The following is a description of a gene set: Prognostic signatures in breast cancer derived from microarray expression profiling have been reported by two independent groups. These signatures, however, have not been validated in external studies, making clinical application problematic. We performed microarray expression profiling of 135 early-stage tumors, from a cohort representative of the demographics of breast cancer. Using a recently proposed semisupervised method, we identified a prognostic signature of genes that significantly correlated with survival (hazard ratio (HR): 5.97, 95% confidence interval: 3.0-11.9, P = 2.7e-07). In multivariate analysis, the signature performed independently of other standard prognostic classifiers such as the Nottingham Prognostic Index and the 'Adjuvant!' software. Using two different prognostic classification schemes and measures, nearest centroid (HR) and risk ordering (D-index), the 70-gene classifier was also found to be prognostic in two independent external data sets. Overall, the 70-gene set was prognostic in our study and the two external studies which collectively include 715 patients. In contrast, we found that the two previously described prognostic gene sets performed less optimally in external validation. Finally, a common prognostic module of genes that associated with survival in both our cohort and the two external data sets was identified. In spite of these results, further studies that profile larger cohorts using a single microarray platform, will be needed before prospective clinical use of molecular classifiers can be contemplated. from publication Naderi A, Teschendorff AE, Barbosa-Morais NL, Pinder SE, Green AR, Powe DG, Robertson JF, Aparicio S, Ellis IO, Brenton JD, Caldas C (PMID 16936776) Down-regulated genes in the breast cancer prognostic signature of genes that significantly correlated with survival. Human Gene Set: NADERI_BREAST_CANCER_PROGNOSIS_DN studied in species Homo sapiens, and this is the list of marker genes: TGFBR3, FBLN1, DCN, C1S, CLK4, TXNIP, MCEE, SPARCL1, SMOC2, NANOG, SSR2, CLDN1, ANXA5, IFT81, SHOX2, REXO2, OMD (osteomodulin), CEBPD